The following is a description of a gene set: The process in which a relatively unspecialized cell acquires the specialized features of a glutamatergic neuron. studied in species Homo sapiens Human Gene Set: GOBP_GLUTAMATERGIC_NEURON_DIFFERENTIATION, and this is the list of marker genes: OPHN1, CABP4, PROX1, IRX5, GNAT2, GRID2, BBS10, ZHX2, WNT7A (NCBI Gene Id 7476), NDP, PRDM1, VSX1, CBLN1, NRXN1, KNDC1, LBX1, RHO, NAGLU, VSX2